Given this list of marker genes SPECC1L, GBA1, CTNNA2, LGI4, WT1, DYNC2I1, INVS, FGFR3, CDC45, WNT3 (NCBI Gene Id 7473), SLC25A24, LONP1, GATA6, MCTP2, ZMPSTE24 (NCBI Gene Id 10269, zinc metallopeptidase STE24), MYH11, PRRX1, WNT7B, LMNA, SF3B2, SCN4A, ITGA8, IFT81, COQ7, AGT, MEG3, ACTA1, MYRF, ALG9, PKHD1, REN (NCBI Gene Id 5972), SETBP1, NUP88, FUZ, TCTN3, NSDHL, TUBA1A, KLHL40, SLC26A2, SLC31A1, VANGL1, RARB, B3GALT6, MKS1, PHGDH, RLIM, ZIC3, GLDN, TRIP11, RTL1, DLK1, PIEZO2, FRAS1, PEX1, KIAA0586, FAM20C, TBX1, SMO, SLC18A3, DZIP1L, ALDH1A2, KIF21A, CC2D2A, AGTR1, DHCR7, KAT6B, PLXND1, TXNDC15, MYOD1, GREB1L, WDR35, TRIP4, ZFPM2, NEK8, CEP120, NPHP3, RYR1, RET, LMOD3, PI4KA, ETFB, PIGN, TMEM94, MUSK, GFRA1, CHRNG, MAGEL2, CEP55, KLHL41, IFT80, AARS2, FANCB, DYNC2H1, MKKS, MYH3, NEB, FLNB, ATP5F1A, ETFA (NCBI Gene Id 2108), LTBP4, ADGRG6, LIFR, BCOR, DPAGT1, ETFDH, WNT4, GLE1, DYNC2I2 (dynein 2 intermediate chain 2), PTH1R, CHRND, RAPSN, STRA6, NAA10, FGF20, WNT9B, HSPG2, TAPT1, ALG3, LBR (lamin B receptor), GRIP1 (NCBI Gene Id 23426), ASCC1, INTU, NEK9, CSPP1, COL2A1, RBM10, ACE, FLNA, FREM2, NEK1, CHRNA1, NKX2-6 (NK2 homeobox 6), DOK7, NDUFB10, DONSON, BMPER, ESAM, here is a description of the gene set: species: Homo sapiens Human Gene Set: HP_PULMONARY_HYPOPLASIA Pulmonary hypoplasia